The following is a description of a gene set: Mouse Gene Set: GOBP_DEOXYGUANOSINE_METABOLIC_PROCESS species: Mus musculus The chemical reactions and pathways involving deoxyguanosine, a nucleoside consisting of the base guanine and the sugar deoxyribose., and this is the list of marker genes: Xdh, Urad (NCBI Gene Id 631440), Gda, Urah (NCBI Gene Id 76974), Uox, Pnp